Given this list of marker genes HRAS, AKT3, SYK, UBB, GRB2, FYN, SOCS2, HCK, CBL, CDKN1B, LCK, FLT3LG, SOCS6, SLA2, PTPN11, PIK3CA, AKT1, UBA52, GAB2 (GRB2 associated binding protein 2), STAT5B, AKT2, RPS27A (NCBI Gene Id 6233), PIK3R1 (NCBI Gene Id 5295), GRAP2, FOXO3, GRB10, SLA, BCL2L11, PTPRJ, CSK, KRAS, STAT5A (signal transducer and activator of transcription 5A), SOS1, SH2B3, NRAS, FLT3, ABL2, UBC, here is a description of the gene set: Feline McDonough Sarcoma-like tyrosine kinase (FLT3) (also known as FLK2 (fetal liver tyrosine kinase 2), STK-1 (stem cell tyrosine kinase 1) or CD135) is a member of the class III receptor tyrosine kinase family involved in the differentiation, proliferation and survival of hematopoietic progenitor cells and of dendritic cells. Upon FLT3 ligand (FL) binding, the receptor forms dimers and is phosphorylated. Consequently, adapter and signaling molecules bind with the active receptor and trigger the activation of various pathways downstream including PI3K/Akt and MAPK cascades (Grafone T et al. 2012). Reactome Pathway: FLT3 Signaling part of: Cytokine Signaling in Immune system species: Homo sapiens